Given this list of marker genes Hspa1a, Hspa1b, Jun, Junb, Zfp36l2, Tsc22d3, Btg2, Klf6, here is a description of the gene set: from publication Cui A, Huang T, Li S, Ma A, Pérez JL, Sander C, Keskin DB, Wu CJ, Fraenkel E, Hacohen N (PMID 38057668) species: Mus musculus Mouse Gene Set: CUI_T_CELL_CD4_IFNK_RESPONSE_DN Cytokines mediate cell-cell communication in the immune system and represent important therapeutic targets. A myriad of studies have highlighted their central role in immune function, yet we lack a global view of the cellular responses of each immune cell type to each cytokine. To address this gap, the authors created the Immune Dictionary, a compendium of single-cell transcriptomic profiles of more than 17 immune cell types in response to each of 86 cytokines (>1,400 cytokine-cell type combinations) in mouse lymph nodes in vivo. A cytokine-centric view of the dictionary revealed that most cytokines induce highly cell-type-specific responses. For example, the inflammatory cytokine interleukin-1β induces distinct gene programmes in almost every cell type. A cell-type-centric view of the dictionary identified more than 66 cytokine-driven cellular polarization states across immune cell types, including previously uncharacterized states such as an interleukin-18-induced polyfunctional natural killer cell state. Genes negatively differentially expressed in cell type: CD4+ T cell upon treatment with cytokine: IFN-κ in mouse lymph nodes in vivo.